Given this list of marker genes Slc9a8, Zfp410, Slc13a5, Sfxn3, Strbp, Slc35e2, Rab43, Slc4a8, Smim1, Ano5, Sema4g, Prpf19, Shroom3, Serinc4, Apc2, Olig3, Rgs9bp, Rab11fip5, Sap30bp (SAP30 binding protein), Zfp81, Smpd3, Cycs, Clock, Mydgf, Rab44, Hspb7, Pom121, Mknk2, Pdgfra, Kcnk13, Itga10, Adamtsl4, Slc35f3, Trps1, Slc38a4, Osbpl9, Raet1e (NCBI Gene Id 379043), Lhpp, Dock3, Akt2, Rgs6, Mrpl15, Raet1d, Crtc3, Inava, Bean1 (NCBI Gene Id 65115, brain expressed, associated with Nedd4, 1), Vps25, Rab11fip3, Camk1d, Sema3f, Snx30, Zcchc14, Prkn, Pitpnm2, Fzd5, Pak5, Sp1, Mkrn1, Entrep3, Otud7b, Mau2, Ikzf4, Pip4p1, Slc2a4, Hectd4 (NCBI Gene Id 676119), Psat1, Mrc2, Afap1l2, Prdm14, Mllt6, Fermt2, Bmp1, Epc1, Dhrs4, Slc12a5, Psd3 (NCBI Gene Id 80295), Rnft2, Tacr1, Spata13, Nfatc1, Pdlim7, Fbxw2, Bace1, 1700012B07Rik, Ppp1r16b, Guk1, Mob3a, Tef, Mpg, Lrrc10b, Fubp3, Ccdc184, Kdm5c, Rasal2, Dbn1, Dnaja3, Mapre3, Dscaml1, Rab15, Strn, Skor1, Mapt, Lpar1, Satb2, 2310057M21Rik, Ell, here is a description of the gene set: species: Mus musculus Genes predicted to be targets of miRBase v22 microRNA mmu_miR_6354 in miRDB v6.0 with MirTarget v4 prediction scores > 80 (high confidence targets). Mouse Gene Set: MIR_6354 from publication Chen Y, Wang X (PMID 31504780)